Given this list of marker genes TAGLN3, PKD1, UBE2D1, EPAS1 (endothelial PAS domain protein 1), RGS5 (regulator of G protein signaling 5), CHL1, PCSK1, KCNA5, ANK3 (ankyrin 3), GNG7, ABLIM1, CADM1, SPOCK1, ELMO1, PRPF6, SPP1, LPL, PRB4, HMOX1, SRPX, APOE, TBR1, RPH3A, MAPT, CA12, GRIK5, PITPNB, TRPM2, SFRP1, TF, RBP1, TSPYL2, MTHFR, SV2B (NCBI Gene Id 9899), QPCT, ZBTB18, ALDH4A1, ENPP2, THBS2, AMPH, TUSC3, HSPA13, EDNRB, LIPA, CLDN10, MBP, WDR7, EPB41L3, ST6GALNAC4, SULT4A1, STMN1, DIRAS3, ATP1B1, FOXG1, HBB, ACTL6B, KDM5D, KCNK1, CCND2, PTN, MAOB, KHDRBS3, ABCA3, CHST15, CCK, KRT17, GABRB3, CX3CR1, CITED1, CYB5R1, RSBN1, RBMS3, DDX3Y, KMT2A, NECAP1, FAT2, MAOA, TYRO3, PCBP4, NCAM1, GSTM1, DKK4, MTUS1, B4GAT1, TNFRSF6B, RHBDL1, IGFBP2, INSM1, MAPRE2, FBXL7, EIF4EBP1 (NCBI Gene Id 1978), COX7A1, DBP, PCK1, PARD6A, HSPA2, PSPHP1 (NCBI Gene Id 8781), CDH4, GRIN1, CRYM, GNG4, WIF1, CKB, POLR2J, TLE2, SCRN1, EFNA2, PSD, MDK, BCL11A, CDH22, IFI27, GPC3, MAP2, TNF (NCBI Gene Id 7124), ITGA7, ITM2A, RCAN2, VCAN, LGR5, PDE4B, GPRC5B, CHN2, NID2, FAM131A, PALM (paralemmin), DCX, EEF1A2, PCDH9, ABLIM3, RAB31, NEURL1, MYRF, TSPAN8, EPHX1, CLEC3B, CELSR3, AKR1C2, SSTR2, LDOC1, CELF2, CTSF, STX1A, RIMS2, KIF3A, DPYSL4, TBC1D9, GADD45G, MACIR, CLDN5, NEFL, CALB2, DUSP5, SLC1A3, SCN2B, SLC6A3, MEF2C, UBL3 (ubiquitin like 3), LMO4, F3, PARM1, ARC, ALDH1A3, GSTA4, PTP4A3, FABP7, LMO2, ACSL1, CYP2F1, PLAAT3, CSPG5, BIN1, TMCC2, GET1, GABBR2, VGF, RIMS3, PPP3CA, ATOSB, GAGE12F, STK39, POMZP3, BICD1 (BICD cargo adaptor 1), SNAP25, RGS4, KRT86, SGCE, TSPYL4, CRABP1, GNAO1, RAC3, FGFR3, GPX3, PLCB1, LDB2, APOC4, FXYD1, SH3GL3, DNAJB2, TENM4, PRKACB, DGCR2, SNCB, EXD2, GAD1, RGS7, NRG2, ZIC2, DMBT1, PHYHIP, RND1 (NCBI Gene Id 27289), GJB1, CNP, INPP1, ARMCX2, PQBP1, DNM1, APLP1, UBXN1, CRYAB, PTPRN2, STAT2, KIF21B, ACSL6, DBN1 (NCBI Gene Id 1627), NNAT, PAX4, CGA, BAIAP3, GNG12, CABP1 (NCBI Gene Id 9478), DPYSL3, AAK1, MLC1, PLXNA2, SOX4, PFKFB4, SLC2A3, SNPH, RUNX1T1, QDPR (quinoid dihydropteridine reductase), PAX6, RNASE1, PLEKHB1, ALCAM, HRAS, SCG5, TIMP3, ABAT, SCG2, IGFBP6, KCNJ4, MAPK8IP2, TMSB15A, NR4A1, TACC2, C3, DYNC1I1, KCTD17, GFPT2, FZR1, ATP2B2, BDH1, SERPINA1, GALR3, SYT5, ARNT2, APC2, DLK1, EPN2, DVL1, CSH2, CACNB3, FAM107A, FOS, CORT, ABCC5, GLRB, PDE2A, NFYC, AKR1C1, NRGN (NCBI Gene Id 4900), FZD7, PRPF19, SCHIP1, SLC39A6, FEZ1, CBR1, ATP9A, APBB1, SYNGR1 (NCBI Gene Id 9145), TMX4, MYO10, PCP4, CHST1, CBLN1, TRO, PER1, CHGA, RASL10A, DTNB, PSG7, SYNE1, BCAS1, FEV, TFAP2B, MAP7, ELAVL4, SORBS2, ANOS1, TTLL1, MEIS2, ELF3, CA11, NOVA2, SIX6, PDGFRA, CRMP1, GRIA2, PRKCZ, NEBL, SOX10, OLFM1, FOXO4, MAPK10, COL9A2, KRT4, DUSP8, RNF144A, ELAVL2 (ELAV like RNA binding protein 2), TRIM2, CD24, ITGA6, GPM6A, LY6H, SLC23A2, TRIM9, BRD4, ANGPT1 (NCBI Gene Id 284), CACNA1A, NUPR1, HTRA1, HPR, CACNA2D2, FADS2, ATP1B2, TRIM23, FAT1, NCALD, PKIA, CDH2, RGS1, KAT6B, SH3BGR, NEFM, PRSS2, SPTBN2, ZP3, SETBP1, MYLK, MAT1A, TIMM17B, THRA, ST18, GABBR1, ZBTB16, ALB, OMG, AQP1, APOC1, L1CAM, AANAT, PTPRD, CDH11 (NCBI Gene Id 1009), MPP3, MYH11, GUCY1B1 (guanylate cyclase 1 soluble subunit beta 1), BMERB1, CHGB, KLHDC3, CHRNB1, TRPC4AP, ARHGDIG, BTBD3, ASCL1, ARHGEF4, NCAN (neurocan, NCBI Gene Id 1463), RASSF2, RALGPS1, IGFBP3, PHLDA1, SEPTIN5, SPHK2, FKBP1B, C1QB, ROR1, MXD4, CSRP2, SCN1B, GJA1, UCHL1, RND3, CALB1, GPRASP1, MLLT11, ZIC1 (NCBI Gene Id 7545), DCLK1, IFIT1, ABCC8, SOX9, PLCH2, GAP43, H2BC21, GATM, CDK18, CACNG3, SERPINA3, CNTNAP2, NECAB3, ITPR1, WASF3, LZTS3, SLC17A7, VSNL1, SERPINI1, SV2A, RHOB, SCAMP5, KYAT1, WFDC2, ST3GAL5, KLK6, SNCG, DLG4, ITPKA, APBA2, ZBTB20, NOVA1, STXBP1, RAB11B, KIF5C, TNC, ELAC2, FOLR2, ATP6V1D, RELN, AGT, RTN1, RPS4Y1, EFNB3, ALDH7A1, FGF9, MTMR9, GRIK1, TM7SF2, SCO2, CPE, PLP1, CORO1A, FGFR1, FGFR2, CEL, STOML1, ASIC1, RYR3, ORM2, TMEM47, SMARCD3, PEG10, NPTX1, FRZB, ALDH1A1, MT1G, ATP6V0A1 (ATPase H+ transporting V0 subunit a1), CA2, SPARCL1, AQP4 (aquaporin 4), MEGF9, PTPRO, SLC22A18AS, MTSS1, PPP4R2, INHBB, STMN2, TLE1, PLXNB1, SNRK, LAMA2, PTGDS, NPY, CLIP3, ADIRF, NTRK2, EDA, HTR4, EFS, ADH1A (NCBI Gene Id 124), NEO1, SPOCK2, LHX2, TSPAN7, SELENOP, HAGH (hydroxyacylglutathione hydrolase), INSIG1, PTK2B, ENO2, CKMT1B, SYT1, SLC1A6, TUBGCP4, GABRG2, TCEAL4, PRAME, MAGI2, PPL, NAP1L3, SLIT1, AMT, CDKN1A, LARGE1, EVI2A, DDX17, PTPRN, IQSEC1, PENK, NHERF1, CFAP410, CBX6, CARTPT, APOD, ATP6V1G2, COL6A2, SOD3, PRKCB, SNAP91, DPP6, AHDC1, SST, COL9A3, FGB, S100B, RUNDC3A, THBS4, NRXN1, EPHA4, CEP135, here is a description of the gene set: Human Gene Set: MODULE_137 species: Homo sapiens CNS genes.